The following is a description of a gene set: Catalysis of an oxidation-reduction (redox) reaction in which hydrogen or electrons are transferred from reduced iron-sulfur protein and one other donor, and one atom of oxygen is incorporated into one donor. Human Gene Set: GOMF_OXIDOREDUCTASE_ACTIVITY_ACTING_ON_PAIRED_DONORS_WITH_INCORPORATION_OR_REDUCTION_OF_MOLECULAR_OXYGEN_REDUCED_IRON_SULFUR_PROTEIN_AS_ONE_DONOR_AND_INCORPORATION_OF_ONE_ATOM_OF_OXYGEN species: Homo sapiens, and this is the list of marker genes: CYP4F2, CYP4F8, CYP27A1, CYP11B1, CYP4A11, CYP4F12, COQ6, CYP4A22, CYP11B2, CYP11A1 (NCBI Gene Id 1583)